Given this list of marker genes Cx3cr1, Serpinb9f, Tusc2, Cxcl9, Igf2, Lyz2, Cd55, H2-T13, Ighg1, H2-M10.2, Klrd1, Mbl2, Pik3r6, Klrb1b, Il13, Nts, Pglyrp4, Cd160, Serpinb9e, Serpinb9h, Nckap1l, H2-M3, Pglyrp1, Emp2, H2-Q2, Ccl19-ps1, Rnf19b, H2-M9, H2bc21, Crk, Kctd9, Atn1, Klrc3, Rpl30, Syk, Ccl27b, Tac1, C3, Hrg, Lyzl6, Il12b, Raet1d, Spag11b, Scnn1b, Defb21, Ccl21a, Ctsc, Irgm2 (NCBI Gene Id 54396), Azgp1, Tyrobp, Klrb1f, Slamf6, C8b, Hmgn2-ps, Il7r, Hamp2, H2-M10.1, Ccl25 (NCBI Gene Id 320542), Gapdh, C8g, Gfus (NCBI Gene Id 22122), Ccl19-ps6, Hc, Cxcl12, P2rx7, Klrc2, Ccl19-ps5, Gzmd, Il21, Sh2d1a, Cd5l, Ccl21e, Sh2d1b1, Vav1, Ccl17, Raet1e, Arrb2, Cd1d1, Gbp7 (NCBI Gene Id 229900), Dnase1l3, Lag3, Prf1, H2-M10.4, H2-T15, Lyz1, Dao, Ltf, Cd59a, H2-K1, Il12a, Klri1, C9, Cadm1, Ccl27al, Ccl27a, H2-Ea, Gzmm, Gzma, Myd88, Gimap3, Gimap5, H2-M2, Hmgn2, Klrb1c, Cfh, Ceacam1, Ccl21f, Ighe, H2-Q7, Pvr, Klrb1, Hsp90ab1 (heat shock protein 90 alpha (cytosolic), class B member 1), Pomc, Klrc1, Lgals3, H2-T3, Il23a, Pik3r1, Serpinb9d, Tap1, Gapdhrt2, H2-Q10, Stat5b, Rab27a, Ptprc, Lyz3, Nectin2, Nlrp6, H2-T5, Hprt1, Trem3, Lamp1, Gapdh-ps15, Clec2d, Fcgr4, Arl8b, Ppbp, H2-T24, Pglyrp3, Nos2, C8a, Stx7 (syntaxin 7), Unc13d, Stat5a, Ccl19-ps4, H2-Q4, Ulbp3, Grb2, Klrb1a, Fadd, 2410137M14Rik, Nppb, Oga, Pla2g2a, F2, Fcgr2b (Fc receptor, IgG, low affinity IIb), H2-M5, H2-T22 (NCBI Gene Id 15051), Gbp5, Spi1, Nectin4, H2-D1, H2-M10.6, H2-Q6, Defa20, Crtam, Cd226, Serpinb9g, Kng2, Ebag9, Ccl21d, Gbp3, Lep, Stxbp2, Apol11a, Kif5b, Ninj1, Fcgr3, Gzmb, H2-M10.5, Gfer, H2-M10.3, H2-M11, Gbp2b, Cxcl14, Sh2d1b2, Clec7a, Cd59b, Cd1d2, Dnase1, H2-Q1, Itgam, Hcst, Cxcl10, Ifng, Ccl8, Pnp, Stx11, Gzmn, Arg1, Mbl1, Ccl1, B2m, Gapdhrt, Gbp2, Ap1g1, Inpp5d (inositol polyphosphate-5-phosphatase D), Cxcl11, H60b, Igtp, Pcyox1l, H60c, Slc22a13, Bad, Il4, Ccl19, Gzmc, Ncr3-ps, Trem1, H2-M1, Pik3cb, Clec12b (C-type lectin domain family 12, member B), Lyst, Camp, Plekhm2, Xcl1, Klre1, Ccl21b, Ccl11, Cxcl5, Cxcl1, Il18, Serpinb9b, Ccl19-ps3, Gm12250, Lgals9, Mill1, Rps19, Ccl20, Mr1, Gzmf, Fgl2, Ccr5, H2-T23, Havcr2, Gzme, H2bc12, Ptpn6, Fcgr1, Ppp3cb, Klrk1, Nkg7, Prdx1, Ccl22, Klri2, Cr1l, Ctsh, Hspa8, Elane, Coro1a, Cd2, Romo1, Cxcl13, Cebpg, Hamp, Ccl28, Ulbp1, Il18rap, Ncf1, Fcer2a, Muc4, Serpinb9, Ripk3, Cyrib, Tgfb1, Defb20, F2rl1, Stap1, Ager, Ccl2, Serpinb9c, Rasgrp1, Cst11, Tap2 (NCBI Gene Id 21355), Kng1, Gzmg, Bcl2l11, Ctsg, here is a description of the gene set: Mouse Gene Set: GOBP_CELL_KILLING species: Mus musculus Any process in an organism that results in the killing of its own cells or those of another organism, including in some cases the death of the other organism. Killing here refers to the induction of death in one cell by another cell, not cell-autonomous death due to internal or other environmental conditions.